The following is a description of a gene set: Human Gene Set: GSE9988_LOW_LPS_VS_VEHICLE_TREATED_MONOCYTE_DN studied in species Homo sapiens Genes down-regulated in comparison of monocytes treated with 1 ng/ml LPS (TLR4 agonist) versus untreated monocytes. TREM-1 is an orphan immunoreceptor expressed on monocytes, macrophages, and neutrophils. TREM-1 associates with and signals via the adapter protein DAP12/TYROBP, which contains an immunoreceptor tyrosine-based activation motif (ITAM). TREM-1 activation by receptor cross-linking is pro-inflammatory, and can amplify cellular responses to Toll-like receptor (TLR) ligands such as bacterial lipopolysaccharide (LPS). To investigate the cellular consequences of TREM-1 activation, we have characterized global gene expression changes in human monocytes in response to TREM-1 cross-linking in comparison to and combined with LPS. Both TREM-1 activation and LPS up-regulate chemokines, cytokines, matrix metalloproteases, and PTGS/COX2, consistent with a core inflammatory response. However, other immunomodulatory factors are selectively induced, including SPP1 and CSF1 (i.e., M-CSF) by TREM-1 activation and IL-23 and CSF3 (i.e., G-CSF) by LPS. Additionally, cross-talk between TREM-1 activation and LPS occurs on multiple levels. While synergy in GM-CSF protein production is reflected in commensurate mRNA abundance, comparable synergy in IL-1b protein production is not. TREM-1 activation also attenuates the induction of some LPS target genes, including those that encode IL-12 cytokine family subunits. Whereas positive TREM-1 outputs are abolished by the PI3K inhibitor wortmannin, this attenuation is largely PI3K-independent. These experiments provide a detailed analysis of the cellular consequences of TREM-1 activation, and highlight some of the complexity in signal integration between ITAM- and TLR-mediated signaling. from publication Dower K, Ellis DK, Saraf K, Jelinsky SA, Lin LL (PMID 18292579), and this is the list of marker genes: FOXK1, USP22, NLRC4, GIT2, PSAP, ARHGAP27, CCR1, DAGLB, TNFRSF1A, CENPB, LAPTM5, APOBR, ZNF780A, RPL27, PGP (NCBI Gene Id 79118), STX6, IFFO1, WBP1L, MPEG1, CTSH, MIGA2, VPS35, PFKFB4, CXCL16, RGS12, TGFBI, PLEKHO2, DDX17, TFEB, ZDHHC7, PPP1R9B, RAB11FIP4, CASP8, TMBIM1, TAF4, RANBP6, OTULINL, FBXO7, TMEM121B, TUSC2, EVI2A, CTSB, CCR2, ARHGAP30, NRDE2, THAP11, ELOVL1, RPS6KA1, UBAC1, SH2D3C, DSTYK, GPX1, DAZAP2, SLC35A2, TACC1 (transforming acidic coiled-coil containing protein 1), PCNX4, GABARAP, DNAJC5, ORAI3, PTP4A2, ATG9A, CHAMP1, S100A6, FAM78A, RNF220, NT5DC2, TWF2, TRAPPC12, PECAM1 (platelet and endothelial cell adhesion molecule 1), CMTM3, IL27RA, ZNF555, EIF3L, PSMC3IP, PCBP1, HECA, RNF8, MYO1F, POU2F1, IFI30, TYROBP, GID4, NLRP12, PURA, RAP2B, TGIF2, RGS19, RPL30, ARL6IP5, CXCR4, PHAF1, ATXN7L3, DEPDC5, RAB5IF, BAZ1B, PHF23, TMEM170B, TCHP, GRN, YWHAG, LAMTOR2, LYL1, STK24, TNFAIP8L2, MED22, DOK3, KLHDC10, SRSF9, WDR33, MAST3, CTDSP1, OLIG1, KLHDC3, MNT, LAPTM4A, ICMT, SDHAP1, CYTIP, DYRK2, BMF, STK11, ENO1, BRI3, DCAF12, CALHM2, RHOG, SERTAD3, LASP1, IRF5, DNAL4, DOK2, ING4, FRAT2, SETD1B, NUP214, RAB31, TCF20, RIPOR1, CTDSP2, SASH3, PDK4, JKAMP, ARPC1B, CLIC1, ZNF318, TIMM21, PPP1CA, MTCH1, ENC1, EXTL3, MAP7D1, MRFAP1, CAPZA1, LFNG (NCBI Gene Id 3955), SNX3, WDR44, GIMAP8, RARA, HINFP, ATOSB, SDHA, SUMO2, SPIDR, APBB1IP, FRAT1, DYNLL1, TSC22D3, ATF5, RBPJ, WIPI2, USP19, PAGR1, TNFAIP8L1, ORAI2, MAP3K3, RALA (RAS like proto-oncogene A), PRELID1, NFIC, TNRC6A, PLXNB2 (NCBI Gene Id 23654), NELFA, CSK, PIP5K1C, MRM2, PPP1R18 (protein phosphatase 1 regulatory subunit 18), HHEX (hematopoietically expressed homeobox), WDR82, PXN, DUSP7, RUNX3, RGP1, PHC2, ARRDC2 (arrestin domain containing 2), OLIG2, ZNF688, KLF13, CX3CR1, S100A11 (S100 calcium binding protein A11), TLR1